Given this list of marker genes H2AZ1, CEBPB, GTF2B, RFX7, PAX6, RUVBL2, GBX2, H3-3B, REST, TBPL1, FOS, GTF2A1, H3-3A, TBP, RELA, STAT1, EZH2, HDAC1, AR, TAF1, POU2F1, here is a description of the gene set: Human Gene Set: GOMF_RNA_POLYMERASE_II_CORE_PROMOTER_SEQUENCE_SPECIFIC_DNA_BINDING studied in species Homo sapiens Binding to a DNA sequence that is part of the core promoter of a RNA polymerase II-transcribed gene.